The following is a description of a gene set: from publication Cui A, Huang T, Li S, Ma A, Pérez JL, Sander C, Keskin DB, Wu CJ, Fraenkel E, Hacohen N (PMID 38057668) Genes positively differentially expressed in cell type: NK cell upon treatment with cytokine: IL-17F in mouse lymph nodes in vivo. Mouse Gene Set: CUI_NK_CELL_IL17F_RESPONSE_UP studied in species Mus musculus Cytokines mediate cell-cell communication in the immune system and represent important therapeutic targets. A myriad of studies have highlighted their central role in immune function, yet we lack a global view of the cellular responses of each immune cell type to each cytokine. To address this gap, the authors created the Immune Dictionary, a compendium of single-cell transcriptomic profiles of more than 17 immune cell types in response to each of 86 cytokines (>1,400 cytokine-cell type combinations) in mouse lymph nodes in vivo. A cytokine-centric view of the dictionary revealed that most cytokines induce highly cell-type-specific responses. For example, the inflammatory cytokine interleukin-1β induces distinct gene programmes in almost every cell type. A cell-type-centric view of the dictionary identified more than 66 cytokine-driven cellular polarization states across immune cell types, including previously uncharacterized states such as an interleukin-18-induced polyfunctional natural killer cell state., and this is the list of marker genes: Phb1, Slamf7, Gin1, Lgals8, Gpatch4 (G patch domain containing 4), Fam162a, Pfn1 (profilin 1)